The following is a description of a gene set: species: Mus musculus Mouse Gene Set: GOBP_PROPRIOCEPTION The series of events by which an organism senses the position, location, orientation, and movement of the body and its parts. Proprioception is mediated by proprioceptors, sensory nerve terminals found in muscles, tendons, and joint capsules, which give information concerning movements and position of the body. The receptors in the labyrinth are sometimes also considered proprioceptors., and this is the list of marker genes: Rnf170, Mecp2, Gbx1, Fxn, Tmem150c, Pou4f1